Given this list of marker genes Psap, Epdr1, Il2, Lamc1, Rtn4r, Lyn, Lama1, Mag, Cel, Lamb1, Clip3, here is a description of the gene set: Binding to glycosphingolipid, a compound with residues of sphingoid and at least one monosaccharide. studied in species Mus musculus Mouse Gene Set: GOMF_GLYCOSPHINGOLIPID_BINDING